Given this list of marker genes IL3, FGF7, PPP2CB, RAPGEF2, BRAF, PTPN11, PSMC6, IL2, PSMC4, SPTBN1, ARL2, TLN1, HRAS, IL17RD, NF1, LYPLA1, FRS3, HGF, FRS2, ARRB1, SPTA1, PAQR3, MAP3K11, PTPN3, IQGAP1, FGF23, PPP2R5D, ICMT, FGF8, IL5RA, KBTBD7, DUSP5, IRS1, FNTA, FGF10, PSMC5, LAMTOR2, TGFA, PSMB2, CAMK2A, PTPRA, SPTBN4, JAK3, PHB1, KL, JAK1, ARRB2, PSMA6, GDNF, MRAS, SPRED1, LRRC7 (NCBI Gene Id 57554), FGFR4, SEM1, RASAL3, SHC2, PSMD6, PSMB4, SHOC2, ARTN, PSMD1, FGF6, NRG2, CSF2RA, CNKSR2, NCAM1, NEFL, DLG1, PTPN7, BRAP, EREG, DUSP6 (NCBI Gene Id 1848), NRTN, IL2RG, IL2RA, PSMB6, FGF18, RASA3, RGL2, FGFR2, FGF3, RET, GFRA4, FGF2, SPTBN2, FN1, EPGN, ACTB, GRIN2D, VWF, UBB, PRKCQ, PRKG2, PPP1CB, ACTG1, ABHD17C, PDGFRA, PDGFRB (platelet derived growth factor receptor beta), CUL3, UBA52, RASA4, IL6ST, CSK, PSMA4, NRG1, RASGRP1, PPP5C, PSMD2, LAT, SHC3, DLG2, LAMTOR3, PPP2CA, PSPN, RASAL1, RAP1B, ITGA2B, PSMD14, IL3RA (NCBI Gene Id 8281), IL2RB, KIT, KITLG, AREG, DLG3, RCE1, NRG4, RASA2, SPTB, PSMB7, DUSP16, PSMA3, BTC, CSF2RB (colony stimulating factor 2 receptor subunit beta), PEA15, DUSP2, PSMB5, MAPK12, HBEGF, VCL, PSMD11, CDK1 (cyclin dependent kinase 1), RASA1 (RAS p21 protein activator 1), PSMD7, PDGFB, PIK3CA, PPP2R1B, ADRM1, SPTBN5, ERBB2, USP17L2, IL6, FGFR1, DLG4, GRIN2B, FGG, ABHD17B, DUSP10, FGF20, CSF2, FGF22 (NCBI Gene Id 27006), PPP2R5C, RALGDS, PSMD12, FYN, SRC, GFRA1, IL6R, CALM1, FGFR3, RGL1, MAP2K1, DUSP9, TYK2, ITGB3, EGFR, RASGEF1A, ARAF, ANGPT1, RASGRP3, KSR1, FLT3, FLT3LG, SYNGAP1, DUSP1, RPS27A, BCL2L1, FGF4, PPP2R5E, KRAS, PSMD8, IL5, PSMB3, PTK2, FGF19 (fibroblast growth factor 19), FGF1, SPRED3, RAP1A, EGF, RASGRF2, PSMA1, ERBB4 (erb-b2 receptor tyrosine kinase 4), MET, WDR83, PSMC1, RAF1, CAMK2D, ZDHHC9, IRS2, RASGRF1, DAB2IP, GFRA3, FGF16, GFRA2, NRAS, RGL3, PDE6D, SPRED2, MAPK3, PSMC2, PSMB1, SHC1, KLB, YWHAB, FGF17, KSR2, PPP1CC, PIK3R2, RASGRP4, MAP2K2, PSMA7, DUSP7, PSMA5, UBC, GOLGA7, RASAL2, FGB, CAMK2G, CAMK2B, CNKSR1, RBX1, GRB2, FGA, JAK2, PSMA2, PDGFA, FNTB, DUSP4, PSMC3 (NCBI Gene Id 96121), PSMD3, GRIN1, NRG3, DUSP8, PIK3CB, PPP2R5A, MAPK1, PPP2R5B, MARK3, PSMD13, SOS1, ABHD17A, SPTAN1, TEK, PIK3R1, PPP2R1A (NCBI Gene Id 5518), FGF5, PEBP1, ERBB3, APBB1IP, RANBP9, FGF9, ACTN2, here is a description of the gene set: species: Homo sapiens part of: MAPK family signaling cascades The extracellular signal regulated kinases (ERKs) 1 and 2, also known as MAPK3 and MAPK1, are phosphorylated by the MAP2Ks 1 and 2 in response to a wide range of extracellular stimuli to promote differentiation, proliferation, cell motility, cell survivial, metabolism and transcription, among others. In the classical pathway, MAPK1/3 activation is triggered by the GEF-mediated activation of RAS at the plasma membrane, leading to the activation of the RAF MAP3Ks. However, many physiological and pathological stimuli have been found to activate MAPK1/3 independently of RAF and RAS, acting instead through MAP3Ks such as MOS, TPL2 and AMPK. Activated MAPK1/3 phosphorylate numerous targets in both the nucleus and cytoplasm. Reactome Pathway: MAPK1/MAPK3 signaling